The following is a description of a gene set: Human Gene Set: HP_CYSTIC_RENAL_DYSPLASIA Cystic renal dysplasia studied in species Homo sapiens, and this is the list of marker genes: MKS1, CPT2, NEK8, BMPER, BICC1, TBC1D24, BBS12, JAM3